Given this list of marker genes VHL, AKT1 (AKT serine/threonine kinase 1), SMARCB1, FOCAD, APC2, LZTR1, CCND1, DDR2 (NCBI Gene Id 4921), NF2, COQ6, NKX2-1 (NCBI Gene Id 7080), CCM2, SIX1, CHRNG, SPRED1, COG1, KDM6A, KARS1, NSD1, NFIX, HRAS, EYA1, SYK, IPO8, PIK3CA, KRIT1, KMT2D, PDCD10, here is a description of the gene set: studied in species Homo sapiens Human Gene Set: HP_NEOPLASM_OF_THE_EAR A tumor (abnormal growth of tissue) of the ear. Neoplasm of the ear